The following is a description of a gene set: part of: Citric acid cycle (TCA cycle) Reactome Pathway: Maturation of TCA enzymes and regulation of TCA cycle This event has been computationally inferred from an event that has been demonstrated in another species.<p>The inference is based on the homology mapping from PANTHER. Briefly, reactions for which all involved PhysicalEntities (in input, output and catalyst) have a mapped orthologue/paralogue (for complexes at least 75% of components must have a mapping) are inferred to the other species. species: Mus musculus electronically inferred by orthology from the curated human pathway, and this is the list of marker genes: Lyrm4, Isca1, Iscu, Fxn, Sdhaf3, Idh2, Sdhaf1, Sdhb, Sdhaf2